Given this list of marker genes CD6, CRKL, SFRP1, GFUS, CEACAM6, MIR92A1 (NCBI Gene Id 407048), HTN1, CCN1, SOX13, APOA1, ADA, MAGI1, NLRP3, WNT10B, PTK2B, SPOCK2, P2RY12, HYAL1, NID1, LILRB4, SASH3, ARID1A, IL1B (NCBI Gene Id 3553), CYLD, IL6ST, IL4R, CBFB, WNT3A (NCBI Gene Id 89780), LYN, BMP7, ADGRG1, HES1, RHOD, SPN, UNC13D, AZU1, EP300, NR4A3, FOXA2, IL2RG, VWC2, RRAS, CARD11 (caspase recruitment domain family member 11), CCL25, DAG1, PTPN23, MYO10, RET, CYRIB, EBI3, FLOT2, HLX, NODAL, CD47, EPB41L4B (erythrocyte membrane protein band 4.1 like 4B), VAV1, COL26A1, IGF1, VTN, PKP3, TNF, PLEKHA2, UTRN, PDPK1, HLA-DPA1, PTPRU, ADAM19, SOCS5 (NCBI Gene Id 9655), FOXA1, BAG4, NOD2, TFRC, PTPRJ, MAP4K4, AMBRA1, HMGB1, NPNT, FUT7, CD44, CD74, LGALS1, ARID2, BTN2A2, IL7R, SIRPG, DENND6A, FUT1, NRG1, SART1, VNN1, FLNA, CLECL1P, SOX12, HSD17B12, EMILIN2, RAC3, RHOA, FGG, IL23R, HRG, ALOX5, SMAD7, RASGRP1, ZP3, AKT1, CD40LG, HLA-DMB, SPTA1, IL18, PCK1, CR1, EPB41L5, WNT5A (NCBI Gene Id 7474), ABL1, LAMB2, CTNNB1, RAC1, CCL19, DPP4, NKAP, CCR2, MAP3K8, IL36B, TNFSF11, COL8A1, LIMS1, EGFL6, RHOH, NCKAP1L, HLA-DRB5, ITGB1BP1, TNFSF14, BMI1, LAMB1, TMEM102, CX3CL1, COL16A1, TRAF6, ACTB, LAMC1, TGM2, DUSP26, CD28, PRKD2, SLC7A1, DISC1, EFNB1, FOXP3, SELE, CD276, GATA3, DSG2, ITGAV, NFKBIZ, CDH13, CDK6 (NCBI Gene Id 1021), LEF1, IL12RB1, MYADM, ABI3BP, ST3GAL4, ITPKB, ACTL6B, PBRM1, CHRD, VEGFA, SMARCC2, NCK1, SERPINF2, NPY2R, NFAT5, SIRPB1, KIF26B, IL4I1, IL6, TYK2, FADD, IL1A, SFN, PIK3R6, PRSS2, CD70, FRMD5, F11R, ANGPT1, PKP1, BCL6, HHLA2, PRKCA, DOCK8 (dedicator of cytokinesis 8), SHB, LGALS8, HSPH1, AP3B1, PDGFB, RASAL3, HLA-G, MTOR, HLA-DQB2, ERBB2, KIFAP3, SHH (NCBI Gene Id 6469), CD81, TFE3, ROCK1, CD36, PDCD1LG2, FSTL3, IRAK1, TSC1, PLPP3, NPY (neuropeptide Y), EMP2, CCL5, LDB1, TRIOBP, S100A10, CD209, HLA-DRB3, EGR3, IL21, THY1, IFNG, SELENOK, IL12A, KLHL25, CD63, GSK3B, GPR65, BRD2, GPAM, TGFB2 (NCBI Gene Id 7042), STAT5B, RIPK2, SMARCA2 (NCBI Gene Id 95083), ADAM9, HTR2A, CD160, CASS4, HAVCR2, HLA-DMA, RREB1, IBSP, ACTL6A, PRKAA1 (protein kinase AMP-activated catalytic subunit alpha 1), IL2RA, IHH, PRKCE, PRKCZ, SOCS1, RAP1GAP, ZBTB16, LAMA2 (NCBI Gene Id 3908), MIR519D, CSF1, IL2, ZBTB1, HLA-E, PIK3CD, FYN, TMIGD2, PTPN11, JUP, KITLG, TPM1, SYK (NCBI Gene Id 6850), CYTH3, GCNT1, CD24 (CD24 molecule), LAMA1, POLDIP2, VAV3, CCR7, ECM2, FOXO3, EPHA1, IL7, DNAJA3 (DnaJ heat shock protein family (Hsp40) member A3), FERMT1, HACD1, PHF10, GLI3, RNASE10 (ribonuclease A family member 10 (inactive)), PRKCQ, SLAMF1 (signaling lymphocytic activation molecule family member 1, NCBI Gene Id 6504), IL6R, HLA-DQA1, DMP1, HLA-DQA2, TNFSF9, DOCK5, CD3E, ZAP70, SOX2, JAK2, MDK, NFKBID, MMRN1, STK4, CFL1, FCHO1, CD86, XCL1, TNFSF13B, RELA, RELL2, AGR2, CD80, FGB, ADAM8, SMARCD3, TEK (TEK receptor tyrosine kinase), LIMS2, EFNB2, ICOSLG, WNT4, GLI2, YES1, ALOX15, OLFM4, IFT74, PTPRC, ITGB2, PDPN, XBP1, HLA-A, C1QBP, B2M, CD46, CD4, CXCL13, LGALS9, HAS2, HSPD1 (heat shock protein family D (Hsp60) member 1), FOXC2, VCAM1, CD5, KLRK1, GP6, KAT5, VSIR, BRAF, SMARCA4, SMARCE1, HLA-DQB1, ILK (integrin linked kinase), ITGB3, DAB2, ELANE, LILRB2, P4HB, CHST4, JAK1, CTSG, ARL2, SMAD3, TNFSF4, MIR128-1, AIF1, FN1, STX4, MIR30B, ANXA1, ETS1, ITGA2, SMARCB1, BCL10, CD274, EGFLAM, SRC, PYCARD, CCDC88B, ANK3, CDC42, ARID1B, RPS3, CCDC80, PIEZO1, EPO, LCK, BRD4 (NCBI Gene Id 90616), CCL21 (NCBI Gene Id 6366), CRK, NRP1 (NCBI Gene Id 8829), FERMT2, IL23A, IL4, VTCN1, AFDN, SIRPA, RARA, FUT3, CALR, CIB1, OPA1, FBXO38, EDIL3, APBB1IP (NCBI Gene Id 54518), ATM, LIF, CAV1, SMARCC1, BRD7, FBLN1, ZBTB7B, PODXL, CORO1A, CARMIL1, ARHGEF7, MALT1, FLOT1, RIN2, FOXF1, IL1RL2, AGER, TNFRSF13C, ARPC2, PTPN6, EFEMP2, DUSP10, IL12B, HLA-DOB, MIR21, CSPG5, TGFBR2, MYOC, CXCL12, GCNT2 (NCBI Gene Id 880), BTNL2, DOCK1, STX3, AP3D1, EMILIN1, TESPA1, MEGF10, PREX1, NCK2, TGFB1, ITGA4, CHST2, TNFSF18, NR5A2, RUNX1, TNFRSF18, ICOS, RSU1, ZMIZ1, BAD, SOX4, SFRP2, KDR, RUNX3, SMARCD2, TJP1, FBLN2, DHPS, RAG1, CITED2, PIK3R2, SKAP1, ABL2, NEDD9, LEP, TNFRSF14, CD83, ITGA3, PPM1F, LILRB1, NDNF, SELP, CCL2, CD1D, CD27, MIR27B, IGFBP2, IL10, ITGA5, MFSD2B (MFSD2 lysolipid transporter B, sphingolipid), STAT5A, KLHL22, FUT4, HLA-DPB1, HLA-DRB1 (NCBI Gene Id 730415), PPP3CA, SDC4, HLA-DRA, ZFHX3, CD55, SAA1, KLRC4-KLRK1 (KLRC4-KLRK1 readthrough), CCL28, FGA, HLA-DOA, VIT, CSK, HLA-DRB4, EPHA4, ZP4, IGF2, SMARCD1, TESK1, PLAUR, PNP (purine nucleoside phosphorylase), IL15, EFNB3, YWHAG, here is a description of the gene set: species: Homo sapiens Human Gene Set: GOBP_POSITIVE_REGULATION_OF_CELL_ADHESION Any process that activates or increases the frequency, rate or extent of cell adhesion.